The following is a description of a gene set: studied in species Homo sapiens Human Gene Set: HP_EMG_ABNORMALITY EMG abnormality Abnormal results of investigations using electromyography (EMG)., and this is the list of marker genes: POMGNT1, GBF1, FRG1, DSP, VPS13A, LARGE1, TPM3, CPT1C, NALCN, UBA1, COL12A1, SGCD, LGI4, VAPB, MT-TK, PRPS1, YARS2, MFN2, MT-TL2, NOP56, PHKA1, TIA1, SGCG, PRDM16, KCNE3, IBA57, RRM2B, CACNA1D, MT-TQ, PLN, KCNJ18, CPLANE1, ATP13A2, CAP2, COQ8A, ANO10, SETX, DISP1, LAMP2, BIN1, ALG2, SLC18A3, VRK1, MT-TF, UNC45B, DOK7, TAF1A, TXNRD2, CYP27A1, MYBPC3, PSEN2, DNMT3B, VCP, BAG5, CHRNB1, MYOT, RAF1, FGFR1, KLHL41, CEP126, MYL1, DYSF (NCBI Gene Id 8291), VAMP1, SGCA, MTMR14, PLOD1, TPM2, GIPC1, TANGO2, SLC33A1, OPTN, NR4A2, SLC12A6, GMPPB, TMEM43, OPA1, RYR1, GNE, MYF6, ANO5, LMNA, SCO2, MT-TP, CLCN1, CHAT, ACAD9, ANXA11, ZFR, GNA11, KLHL9, DYNC1H1, AK9 (adenylate kinase 9), ALG14, MSTO1, DMXL2 (Dmx like 2), ABCC9, CRIPTO, CDON, MT-RNR1, SNUPN, SLC16A1 (NCBI Gene Id 6566), OAT, PLEKHG5, SMN2, TTN, SLC25A4, COL6A1, POMT2, LAMA4, SIX3, PUS1, SPTLC1, SPG11, ZIC2, SNAP25, SYNE1, EMD, NOTCH2NLC, TCAP, SMCHD1, ARSA, DLL1 (delta like canonical Notch ligand 1), TAFAZZIN, RBM20, GFPT1, POLG, TFG, NEB, ALS2, UNC80, MEGF10, ACTC1, FBXO38, PTCH1, LDB3, SDHA, SLC5A7, LAMB1, TBCE, LAMB2, DHX16 (NCBI Gene Id 8449), ORAI1, TPM1, RTN2, MT-TS2, FLNC, GATAD1, DNM2, CASQ1 (calsequestrin 1), ACTN2, ADCY6, PSEN1, PDK3, PPCS, NODAL, ACTA1, ASAH1, SVIL, ABHD5 (NCBI Gene Id 51099), DPAGT1, DSG2, SAR1B, SLC25A1, GLI2, CASR, JPH2, SEPTIN9, SHH, MYO9A, WASHC5, FKRP, GJB1, LAMA2, TMPO, HSPG2, HSPB1, SYNE2, MAFB, TNPO3, TEFM (transcription elongation factor, mitochondrial), DMD, TNNT2 (troponin T2, cardiac type), MYPN, NEFL, BAG3, PNPT1, CNTNAP1, MT-TL1 (NCBI Gene Id 4567, mitochondrially encoded tRNA-Leu (UUA/G) 1), COL25A1, POLG2, ANKRD1, SPG7, LRP4, MT-TN, MT-TH, KCNA1, TK2, FOXH1, SCN4A, SPTLC2, GDAP1, DNAJB4, DUX4L1, HNRNPA1, SQSTM1, NEFH, GBE1, TNNI3, GAS1, PLA2G6, SCN5A, HNRNPA2B1, MUSK, TNNT1, MT-ATP8, CHCHD10, CHRND (cholinergic receptor nicotinic delta subunit), ALDOA, PHKG1, DCAF8, TWNK, RPL3L, HINT1, MYBPC1, KPNA3, CHRNA1, DOLK, TBCK, COL13A1, DES, SUFU (SUFU negative regulator of hedgehog signaling), SCYL2, ERGIC1, IGHMBP2, CAV3, ATP7A, HSPB8, VEZF1, STIM1, FKTN, DUX4, SMN1, MT-ND5, PMP22, TPP1, FXR1, COL6A3, B3GALNT2, ELP1 (NCBI Gene Id 8518), CRPPA, SMAD4, SPEG, RILPL1, TGIF1, ATP2A1, GYG1, HSPB3, VWA1, HAND2, MYH7, SYT2, MYH6, CRYAB, SH3TC2, PLEC, CACNA1S, TRIP4, AGRN, FHL1, ATXN3, NEXN, KBTBD13, RAPSN, TRIM32, TNNC1, COL6A2, LRP12, MPV17, MYH14, POMT1, ATL1, PSAP, VCL, CHRNE, COLQ, FHL2, ATL3, ADSS1, GABRA3, GET3, JAG2, UBAP1, LMOD2, MATR3, CSRP3 (NCBI Gene Id 8048), FGF8